The following is a description of a gene set: Catalysis of the release of ammonia or one of its derivatives, with the formation of a double bond or ring. Enzymes with this activity may catalyze the actual elimination of the ammonia, amine or amide, e.g. CH-CH(-NH-R) = C=CH- + NH2-R. Others, however, catalyze elimination of another component, e.g. water, which is followed by spontaneous reactions that lead to breakage of the C-N bond, e.g. L-serine ammonia-lyase (EC:4.3.1.17), so that the overall reaction is C(-OH)-CH(-NH2) = CH2-CO- + NH3, i.e. an elimination with rearrangement. The sub-subclasses of EC:4.3 are the ammonia-lyases (EC:4.3.1), lyases acting on amides, amidines, etc. (EC:4.3.2), the amine-lyases (EC:4.3.3), and other carbon-nitrogen lyases (EC:4.3.99). species: Homo sapiens Human Gene Set: GOMF_CARBON_NITROGEN_LYASE_ACTIVITY, and this is the list of marker genes: GGCT, SDSL, ASL, HAL, FTCD, GGACT, PAM, CHAC2, ADSL, CHAC1, SDS, SRR